Given this list of marker genes UMOD, ATP1B1, REEP2, RFTN1, CD24 (CD24 molecule), here is a description of the gene set: species: Homo sapiens Human Gene Set: GOBP_PROTEIN_TRANSPORT_INTO_MEMBRANE_RAFT The directed movement of a protein into a membrane raft. Membrane rafts are small (10-200 nm), heterogeneous, highly dynamic, sterol- and sphingolipid-enriched membrane domains that compartmentalize cellular processes.